The following is a description of a gene set: studied in species Homo sapiens The orderly movement of a Schwann cell from one site to another. A Schwann cell is a glial cell that ensheathes axons of neuron in the peripheral nervous system and is necessary for their maintenance and function. Human Gene Set: GOBP_SCHWANN_CELL_MIGRATION, and this is the list of marker genes: CERS2, RRAS2 (NCBI Gene Id 22800), RRAS, MIR221, MIR222, NF1